Given this list of marker genes SNX10, IFT80, TCIRG1, TNFSF11, FAM20A, here is a description of the gene set: The tooth development process in which the teeth enter the mouth and become visible. species: Homo sapiens Human Gene Set: GOBP_TOOTH_ERUPTION